The following is a description of a gene set: Any process that results in a change in state or activity of a cell or an organism (in terms of movement, secretion, enzyme production, gene expression, etc.) as a result of an ATP (adenosine 5'-triphosphate) stimulus. Mouse Gene Set: GOBP_RESPONSE_TO_ATP studied in species Mus musculus, and this is the list of marker genes: P2rx4, Ccl2, P2rx7, P2rx5, P2rx1, Panx1, Ssh1, Slc8a1, Top2b (NCBI Gene Id 319393), Casp1, Plcg2, P2rx6, Trpv1, P2rx2, Cib2, Ptgs2, Trpm4, Ryr3, Trpc3, P2ry12, P2rx3, Hsp90b1, Sell, Nt5e, Ryr1, Kcnj8, Pklr, Kcnj11, Asph, Pdxp, Abcc9, Dgkq, Il1b (interleukin 1 beta), Dntt